Given this list of marker genes Rb1cc1, Glb1 (NCBI Gene Id 12094), Bad, Ppp1cb, Gm1110, Mgam, Gpd1, Pklr, Aldoc, Atg3 (autophagy related 3), Gapdhs, Enpp1, Fbp1, Aldh1a7, Gapdhrt2, Pfkfb1, Dhdh, Mtor, Adrb1, Wipi1, Aldob, Gk2 (glycerol kinase 2), Man2b2, Prkaa2, Pgam2, Hdac4, Arnt, Phka1, Stbd1, Gpi1, Prkag2, Eno4, Sis, Phkg1, Insr, Hkdc1, Wipi2, Slc4a1, Mlxipl, Atg2a, Src, Actn3, Hk1, Treh, Gk5, Rbks, Galm, Ncor1, Stat3, Ctbs, Eno1, Slc2a6, Gabarapl1, Myog, Pgm1, Agl, Trim63, Sirt6, P2rx7, Chia1, Eno1b, Pkm, Jmjd8, Pygl, Zbtb7a, Manba, Ins1, Tkfc, Aldoart1, Bcl2l13, Kat2b, Gm2a, Pfkl, Galt, Sord, Wdr45, Pfkm, Dhtkd1, Gapdh, Neu4, Arl2, Glb1l3, Naga, Nudt5, Ppp1r3c, Gck, Chit1, Lct, Hk2, Glb1l2, Aldh1a1, Eno3, Man2b1, Pfkfb2, Ddit4, Gpd2, Flcn, Pgm2, Slc4a4, App, Neu3, Ppp1r3e, Zbtb20, Tpi1, Foxk1, Neu2, Wdr45b, Ogt, Galk1, Git1, Scarb2, Adcy10, Pfkfb3, Khk, Ifng, Glb1l, Atg2b, Eif6, Adra1b, Psen1, Pygm, Ppp1ca, Hif1a, Tigar, Atg12, Aldoart2, Mtch2, Mfsd8, Lipa, Hk3, Trex1, Ppargc1a, Ppp1r3d, Uchl1, Ppp2ca, Lrp5, Pfkp, Phkb, Il3, Sik2, Pgk1, Rptor, Dera, Myc, Ucp2, Ogdh, Trp53 (transformation related protein 53), Adpgk, Amy2a5, Gaa, Neu1, Foxk2, Mlx, G6pc1, Prkag3, Hexb, Pgk2, Ldha, Glyctk, Pgam1, Nupr1, Ppp1r3b, Ins2, Cbfa2t3, Hsd11b1 (hydroxysteroid 11-beta dehydrogenase 1), Htr2a, Fkrp, Ep300, Prkaca, Ppara, Gale, Gk, Prkag1, Eno2, Phkg2 (NCBI Gene Id 68961, phosphorylase kinase, gamma 2 (testis)), Esrrb (estrogen related receptor, beta), Igf1, Aldoa, Col6a1, Chil3, Mlst8, Man2c1, Bpgm, Gapdhrt, Slc25a12, Pygb, Ier3, Mpi, Hmgb1, Prkaa1, Prxl2c, here is a description of the gene set: Mouse Gene Set: GOBP_CARBOHYDRATE_CATABOLIC_PROCESS The chemical reactions and pathways resulting in the breakdown of carbohydrates, any of a group of organic compounds based of the general formula Cx(H2O)y. species: Mus musculus